The following is a description of a gene set: species: Homo sapiens Any process that modulates the frequency, rate or extent of anatomical structure morphogenesis. Human Gene Set: GOBP_REGULATION_OF_ANATOMICAL_STRUCTURE_MORPHOGENESIS, and this is the list of marker genes: PDCD10, BMPR1A, MYDGF, NSMF, FGF13, FGD3 (NCBI Gene Id 89846), OSR1, FIS1, SEMA3E, ACVRL1, C3, JAG1, RYK, SEMA7A, CACNG7 (calcium voltage-gated channel auxiliary subunit gamma 7), IL1A (NCBI Gene Id 3552), ARMCX5-GPRASP2, CCR2, KLF4, SPHK1, MYH9, SOX9, TLX2, BMP7, DLL1, BMP4, RHOQ, RELN, TJP1, MIR640, MIR377, RAC2, MARCHF5, MIR495, ERBB2, ETS1, SEPTIN7, CPNE9, PAK4, PARP6, PALMD, RRAS, YPEL4, PLD6, NINJ1, ERAP1, CORO1B, PTGIS, FOXA2, ADM, NOS3, TERT, PARVB, ROBO1, CYRIB, SEMA5A, ZMYM6, HUWE1, SPRY2, ANXA3, IRGM, CUX2, RAPGEF3, VASH2, SYT1, HGS, STAU2, CDC42EP2, ANGPTL4, PIK3CG, PSEN1, THBS1, WDR1, PRKD2, LPAR3, SCX, HRG, PAK1, DVL3, PAK2, FLT4, MSX1, EMILIN1, KIF13B, NLGN1, PKM, WNT4, NRP1, NTN1, SIX1, MAP1B, LBX2, HMGB1, ZRANB1, PAX9, ALOX5, ANGPTL3, CEMIP2, EFNA5, CST3 (NCBI Gene Id 1471), CNTN2, GORASP1, POU4F2, MIR199B, GHRL, TBX2 (T-box transcription factor 2), SYT2, KNDC1, SYT3, DAB2IP, MIR126, JMJD8, MIR145, BMPER, RUFY3, PARVA, YWHAH, NTRK2, SEMA3F, MIEF1, PDPK1, E2F2, MIR200B, SIX2, CTNND1, RAP2A, ARHGEF18, SLC30A1 (NCBI Gene Id 7779), MIR23A, MSTO1, IL1B, GATA5, MAP2K2, CDC42EP3, FAM171A1, FGD4, BCL6, TGFB2 (transforming growth factor beta 2), FOXO4, RAC1, FGF10, PALM, PGAM5, DCN, METRN, MIR125A, SPTA1, XBP1, SMAD1, COL4A3, RLN2, MIR1-1, MIR885, SPRY3, PLXNB1, EPHB3, DPYSL5, RACK1, TMBIM1, MIR199A1, GRIP1, DDAH1, SYNGAP1, EFNA3, MIR18A, PRL, TRPC5, GRN, MIR10A, ADAMTS1, TGM2, CDC42EP5, MIR221, CDC42EP1 (NCBI Gene Id 129136), STIM1, MIR153-1, NFATC4, CCL7, CDH5, BCL11A, TSPAN12, CXCL8, MAPK7, IL10, EPHB2, SP100, CITED2, ZEB2, MIR15A, CCM2, BMP2, MIR503, PAX2, JHY, CHN1, F11R, NHERF1, CYBB, PF4, DDHD1, RHOBTB2, ANAPC2, DLG4, DKK1, AJAP1, WNT5B, FGD5, IL1RAPL1, NPPB, ADGRA2, APELA, GJA1, EMC10, PLXNC1, LST1, PLK2, EMP2, PAX8, SPIRE1, ITGA5, MIR494, LZTS1, AMOT, SARM1 (sterile alpha and TIR motif containing 1), WNT2, ARHGAP4, SRF (serum response factor), ISL1, CHI3L1, ISM1, GATA4, EPB42, KLK3, CFL1, ISLR2, SH3KBP1, SLITRK1, IL6, SERPINF1, ADAM12, SMO, HOXC11, BCL9L, TRIM46 (NCBI Gene Id 80128), MYO10, MIR132, PKN1, SPP1, GDF2, NEUROG3, MIR424, EZR, ABCC8, EEF2K, DLG1, RHOJ, SLC26A5, CDC42EP4, WNT3A, MT3, RET, EGLN1, ENG, RDX, GAS2, ERMN, CDK5R1, TNF, MIR217, MIR16-1, GHSR, OR10J5, SLIT1 (slit guidance ligand 1), MIR9-1, WNT2B, MIRLET7G, CAPRIN2, DNMBP, FBXW8, S100A1, GNA13, SAPCD2, SLC12A2, EPHA7, SASH1, TWIST1, MIR138-1, GATA6, WASF3 (NCBI Gene Id 10810), MAP6, MIR34A, CLIC3, ABI2, HIPK2, NF2, LCN2, RNH1, CUX1, FMNL1, RAPGEF2, PTK2, ADGRB1, MIR125B1, RC3H1, EPS8, MCU, ATP10A, ARHGEF7, RNF6, FGF2, CCL2, LRRK2, TRPV2, WDPCP, PHIP, SFRP2, NR2E1, ABL1, MOV10, HIF1A, FASLG (NCBI Gene Id 356), FOXP1, ATP2B4, ADA, AGO1, MIR29A, SPARC, NAXE, DTNBP1, PIK3R6, MIR210 (NCBI Gene Id 406992), CHRNB2, FUT1, TMEM135, SULF1, HOXA11, COCH, BTBD7, STRIP2 (NCBI Gene Id 57464), MIR27B, TRAK1 (NCBI Gene Id 22906), SIX4, MIR375, EPHA4, DKK4, CCL3, LIMK1, MESP1, HPN, NOTCH1, HLA-G, EMILIN2, SARS1, HGF, SEC24B, ARHGAP35 (NCBI Gene Id 79266), LRRC4C, DSCAM, TIAM1, PKHD1, HOXB7, CCR3, MIR1908, CXCL13, HOXD13, MIR143, LARP4, BDNF, ZNF304, CXCR3, SYT17, RUNX2, KIT, PLCG1, CCBE1, VEGFA, MIR329-1, TENM4, NEDD4, DIP2B, MPL, EPB41L3, FBLN5, PRKN, DHX36 (DEAH-box helicase 36), YME1L1, GATA2, AGT, MIR20A, DISC1 (NCBI Gene Id 80138), LRP8, PTPRD, PEAK3, TACSTD2, MIR31, CDK5, GOLGA4, PDCL3, NEDD4L, L1CAM, SEMA6D, TGFB1, CLDN5, FGR, PPFIA2, PUM2, TLR3, MIR106B, MIR505, HOXA5, CDX2, ECSCR, KIAA0319, C3AR1, DIAPH1, PDGFA, PPP3CA, SP6, ULK2, NOG, EPN1, VPS35, RNF207, VEGFB, MAGED1, DVL1, FOXJ1, GAB1, RAMP2, RALA, CDC42SE2, LZTS3 (leucine zipper tumor suppressor family member 3), RUNX1, CAMP, HK2, PLAA, MAPT, OTX2, PDZD8, ENPP2, PAK3, PTPRS, FGD6, CDKL3, OSTN, ARHGAP18, CDKL5, ADCY10, ADGRG6, ADGRB3, RGCC, TBXA2R, CCL13, RHOB, SFRP1, MIR212, GNA12, FMNL3, THBS2, TBCCD1, NPR1, EFNB3, PRKCA, CLDN4, ITGB3, SP1, MFSD2A, HTN1, JCAD, QKI, MIR185, CLDN3, NGEF, ANKRD27, MUL1, ZMPSTE24, RASA1, CCL24, FRS2, FOXJ2, ARHGAP15 (Rho GTPase activating protein 15), TFRC, SYNE3, RALBP1, RSPO2, MEF2C, NGFR, RGMA, POU3F2, TNN, COL4A2, ARHGAP33, SHANK3, MIR492, DSG2, PTPN6, SRCIN1, ZC3H12A, CAMK2B, MYH10, SIRT6, BRSK1, TRPC6, RASAL1, CAMSAP1, HMOX1, HSPG2, STAB1, ATG16L1, THBS4, C5AR1, LRG1, ZNF354C, CD36, ROBO2, MYO9A, SEMA4A, SHTN1, FOXC2, PDCD6 (programmed cell death 6), ITGB8, FLT1, GADD45A, DMRT2, ZMYM3, CXCL10, TGIF2, GSK3B, HES1, TAFA5, MIR1224, SKIL, ADCK1, HYAL1, NFATC3, HEXB, PRKCB, SPART, TMIGD2, MECP2, MIR361, ZNF135, WARS1, ADAMTS12, PLXNB2, POGLUT1, MTCH2, AQP1, SKOR2, PROK1, FGF7, KDR, F3, SPRED1, ANXA1, FGF18, CPNE5, LIMD1, SIPA1L1, RNF157, CAPRIN1, VASH1, PALM2AKAP2, PINK1, MMRN2, TBX1, CRABP2, TRAK2, TNFSF13B (TNF superfamily member 13b), FKBPL, CREB3L1, KIF1A, SH3D19, DMRT3, BRAF, FGD2, PTEN, BAMBI, EDN1, CEACAM1, TGIF1, ECM1, MIR30A, ALDOA, WNT7A, PGK1, CDH1, LHX1, WTIP, THY1, ANGPT2, HHEX, MAP3K13, GLUL, AHI1 (NCBI Gene Id 54806), VEGFC, CHRNA3, NRDC, STAT3, GDI1, SEMA6A, DVL2, HNF4A, EPHA1, KRIT1, RTN4, WNT5A, MIR451A, SIRT1, TBC1D24, WT1, TEK, PRAG1, FN1, MIR99B, CX3CL1, ADM2, TNFRSF11B, ETV5, FYN, MIR15B, KRT1, KEL, IL17F, PLXND1, TNFSF12, HIPK1, SRC, SEMA4D, DMTN, MSN (NCBI Gene Id 4478), MIR205, MIR29B1, RECK, LGR4, NUMBL, NTRK3, BTG1, BAIAP2, CUL7, MIRLET7B, SEMA3G, CORO1C, MIR146A, SEMA4F, CRK, CTNNB1, GPRASP3, RIMS2, STK25, GREM1, SYNJ2BP, HMGA2, FES, SPAG9, UNC13A, FSTL4, MIR939, NFE2L2, RHOU, OMA1, FOXC1, MINAR1, PRKDC, RTN4R, HDAC6, MIR1298, OBSL1, CDX1, CD40 (CD40 molecule), MIR20B, ABI3, ID1, APOH, MIR378A, ADAMTS9, CNMD, UST (uronyl 2-sulfotransferase), STAT1, PHB2, RHOBTB1, TWF2, CAV3 (caveolin 3), CAPZB, JAK1 (NCBI Gene Id 3716), STAT2, GPR4, EGF, GPNMB, TPM1, MIR30B, CDH4, RHOG (ras homolog family member G), BRWD1, GATA3, ANGPT4, BVES, ARAP1, SYT4, S100B, PALM3, PID1, ADNP, MIR21, DCC, IST1, PTPRM, CMA1, TAOK2, DNM1L, EPHA2, NODAL, GTF2I, SHOX2, WARS2, FITM2, HECW2, DRAXIN, MIR181B1, VAT1, TGFBR2, CD160, EPN2, BRSK2, BCR, HCK, SS18L1, MIR29C, SMURF1, MAP2K1, MYL12B, NEFL, STOX1, ITGB1, MKLN1, MIR19A, CFAP410, PDLIM5, AURKA, HSPB1 (NCBI Gene Id 3315), APLNR, C15orf62, ULK1, PTK2B, DBN1, MIR137, AGO4, CHRNA7, ITGA7, SOX8, NIN, CFDP1, XK, ITPKA (inositol-trisphosphate 3-kinase A), KANK1, MIR34C, DAB1, WNK1, SMOC2, GDNF, TIAM2, PPP1R16B (NCBI Gene Id 26051), HECW1, STRIP1, NF1, FGF16, MIR193A, IFRD1, PQBP1, FMNL2, SHROOM3, APCDD1, SLIT2, STK11, FGF8, BRWD3, PLEKHO1, TNMD, CD34, MTDH, SHH, TNIK, SERPINE1, MIR222, SEMA6C, MCF2, LRP4, MYO19, P2RY1, PLXNB3, ITSN2, TSPAN18, CDC42SE1, FERMT2, CD44, RND2, MYH14, CYFIP1, ZFYVE27, SLC23A2, PDPN, MEGF8, PAFAH1B1, AKT3, AGO2, LFNG, C11orf65, RREB1, MIR17, SHC1, INF2, TIE1, NTN4, ITGB2, WNT10A, SPINK5 (NCBI Gene Id 50962), FBLIM1, YJEFN3, MAG, ROCK2, VANGL2, F2, TNR, MFF, PML, OPTC, CORO1A, TANC2, HSPB6, CELA1, RAB21, CCN6, FGFR1, PRPF40A, CCL11, ZDHHC15, BRCA1, NGF, RIMS1, NTNG1 (NCBI Gene Id 22854), AGGF1, LIF, STARD13, DAPK3, CPNE6, FGFR2, FGF1, PRKD1, CXCL12, MIR487B (microRNA 487b), JUP, ARC, LEP, ROCK1, ARHGAP44, MARK2, LPAR1, ESR1, MDK, VIL1, MIR130A, SNAI2, WNT3, TNFRSF12A, PIK3CD, MACF1, ZMYM4, NTNG2, MIR30E, FZD4, CSF1, ADGRB2, CX3CR1, NTRK1, ARPIN, MIR30C1, PIK3CB, AR, MIR24-1, PPARG, MAP2, AGTR2, TNFAIP3, SPRY1, CRB2, DDHD2, CYP1B1, CSF1R, NKX6-3, PDE3B, PLXNA3, MIR92A1, MIR214, AMIGO1, FUZ, EFNA1, RELA, ITGAX, CHODL (chondrolectin), EFNB2, POU5F1, FGD1, KLF2, MIR34B, BNIP3, RAC3, PARVG, SDC2, BMPR2, ATF2, SYT14P1, ZDHHC6, MIEF2